The following is a description of a gene set: Human Gene Set: GOCC_CYTOPLASMIC_SIDE_OF_LYSOSOMAL_MEMBRANE studied in species Homo sapiens The side (leaflet) of the lysosomal membrane that faces the cytoplasm., and this is the list of marker genes: EEF1A2, GFAP, BLOC1S2, LITAF, CDIP1 (cell death inducing p53 target 1), LITAFD, BORCS5, BORCS8, BORCS7, KXD1, BLOC1S1, EEF1A1 (eukaryotic translation elongation factor 1 alpha 1), SNAPIN, BORCS6